The following is a description of a gene set: Human Gene Set: NGFIC_01 species: Homo sapiens Genes having at least one occurrence of the motif WTGCGTGGGYGG in the regions spanning 4 kb centered on their transcription starting sites. This matches the EGR4 transcription factor binding site V$NGFIC_01 (v7.4 TRANSFAC)., and this is the list of marker genes: CGGBP1, CAND1, KCNA1, FEV, HRK, EGR3, TRIM55, CRY2, SHF, GABARAPL2, KAT7, ELMOD1, CNOT6L, ELAVL3, OTP, FAF1, TBX2, SH3GL3, ZNF232, TP53I11, NFYC, FKBP2, AMMECR1L, CSRNP1, RELB, ICAM5, RBBP6, ACTN1, G3BP2, MADD, ZCCHC12, MACO1, KLF3-AS1, RFX4, ERBB3, LRP10, PPP1R12A, BDNF, PCSK2, GSE1, PTMS (parathymosin), GLRA3, PIK3IP1, PJA1, RAB2A, UCHL3, PSME3IP1, SPTB, TPM4, MATR3, CDK17, WDR44, ADSS2 (adenylosuccinate synthase 2), KCNQ5, GRB2, TFAP4, RHOB (NCBI Gene Id 388), BCL6, CRTC2, SCAI, SH3BP1, TUBA1B, ATG12, ZBTB2, MMP1, ZNF827, BCL6B, PITPNA, AP3S1, IGF2BP1, NRDC, HOXA2, CORO1C, XK, CACNA1E, ZNHIT1, MPC2, SREBF2, RPUSD4, OTX1, C9orf72, GNL1, RPS6KA3, TRIB1, NUDT11, HMGN2, TUG1, NDUFA4L2, REXO2, ZFPM1, ACE, PITX2, BHLHE40, EHBP1, LRRC4, BCL11B, SLF2, AHNAK, ORC4, ASB7, AP1G1 (NCBI Gene Id 164), NPAS4, CDKN2C, KDM3B, LEF1, MAN2A2 (mannosidase alpha class 2A member 2), SYNCRIP, UBTF, SUN2, MYB, CX3CL1, STARD13, PRRT2, PLEKHH3, FUS (NCBI Gene Id 406232), KCNC1, PABPC1 (poly(A) binding protein cytoplasmic 1), KLF3, KCNH3, KCND2, TBC1D10A, JADE2, GUCY1A2, CACNA1A, GRIN1, NFE2L1, EFEMP2, HNRNPR, SMYD5, ZMYM2, PRPF3, PRR3, TRA2B, L1CAM, RTL9, NAT8L, STC2, CLTC, LASP1, EGR1 (NCBI Gene Id 1958), ATP1B2, RRBP1, TLE3, MRPL14, NUDT10, RSPRY1, DCX, SLC25A5, ERF, WNT1, MAP3K4, AGAP1 (NCBI Gene Id 22851), TAF8, ARHGAP12, TLE4, AMOT, ARF3, CEP70, ATOSB, RELA, MNT, SERTAD1, NTN1 (NCBI Gene Id 9423), PCDH17, BMPR2, ZHX2, CD40LG, LINS1, TXNDC12, RASGEF1A, HDAC9, KCNB1, SELENOF, VAX1, SNAP25, MEF2C, TTC9C, PTPN7, TPGS2 (NCBI Gene Id 25941), NRGN, JPH1, NUFIP2, SH3KBP1, HOXA7, SEC14L1, MSI1, HAS1, KCNJ1, SUMO2, PDCD1, WASHC4, ATL1, IP6K2, SIK2, PNKD, DAGLA, HNRNPDL, WDR48, DIAPH1, CNNM4, NTRK3, HOXB7, SMAD3, PABIR2, UBASH3B, KCNS2, PDGFB, SIN3A, GIT1, LRATD2, KCNN2, AAMP, PLOD3, MAP3K5, RALGPS2, PCIF1, DVL2, KCNS3, CLSTN1, SRCIN1, ATP5MC1, HYAL2, VGF, TNFRSF12A, CA11, KREMEN2, POU3F1, ERGIC3, ETF1, BRWD3, PCDHAC2, RBM26, EGLN2, APP, BAHD1, LUC7L2, APLP2, AGAP3, EIF5A, SLC22A17, REL, NLK, KCNIP2 (NCBI Gene Id 30819), LRFN5, SLC25A39, QRICH1, LANCL3, GABRB1, SAP130, GNAI2, PABIR1, CDH2, TSR1, FASLG, KDM2A, COL27A1